Given this list of marker genes TUBA3D, TUBB1, TUBB8, TUBA3C, TUBA4A, TUBB4B, TUBA1A, TUBA1B, TUBB, TUBB6, TUBB4A, TUBB2A, TUBA1C, TUBB3, TUBA8, TUBB2B, TUBA3E, here is a description of the gene set: Escherichia EspG to Microtubule-RHOA signaling pathway. Pathway ID: N01286. Pathway type: Pathogen. Pathway class: nt06135 Cytoskeletal regulation (viruses and bacteria). Human Gene Set: KEGG_MEDICUS_PATHOGEN_ESCHERICHIA_ESPG_TO_MICROTUBULE_RHOA_SIGNALING_PATHWAY studied in species Homo sapiens Pathway Definition from KEGG: (EspG,EspG2) -| (TUBA+TUBB)